The following is a description of a gene set: Switching of origins to a post-replicative state Mouse Gene Set: REACTOME_SWITCHING_OF_ORIGINS_TO_A_POST_REPLICATIVE_STATE studied in species Mus musculus, and this is the list of marker genes: Ccne2, Cul1, Ccna1, Psmb5, Mcm5, Psmc5, Psmd11, Psma2, Psmd6, Ccna2, Uba52rt, Psmb3, Mcm8, Psmb4, Psmd3, Cdc23, Psmd13, Anapc7, Mcm3, Ube2d1, Ubc, Mcm2 (minichromosome maintenance complex component 2), Ube2c, Psma6, Orc4, Psma4 (NCBI Gene Id 26441), Anapc10, Uba52, Cdk2, Cdt1, Ccne1, Psmd7, Cdc26, Psmc1, Anapc16, Psmc4, Psmd12, Anapc15, Psmc3, Ube2s, Skp1, Psmc2, Mcm6, Cdc16, Anapc11, Orc2, Rbx1, Psma3, Skp2, Psma1, Rps27a, Mcm7, Anapc4, Psmd1, Anapc1 (anaphase promoting complex subunit 1), Psmd8, Ubb, Fzr1, Orc5, Gmnn, Orc6, Adrm1, Psmb6, Orc3 (origin recognition complex, subunit 3), Mcm4, Orc1, Anapc2, Psmd2, Cdc6, Psmb2, Psmd14, Ube2e1, Anapc5, Psmb7, Psma5, Psmb1, Psma7, Psmc6, Cdc27